Given this list of marker genes TFAP2C, CBFA2T2, POU5F1, PRDM1, TET2, SOX17, CXCR4, PDPN, NANOG, NANOS3, EOMES (NCBI Gene Id 8320), BMP4, here is a description of the gene set: Human Gene Set: REACTOME_SPECIFICATION_OF_PRIMORDIAL_GERM_CELLS Specification of primordial germ cells species: Homo sapiens